The following is a description of a gene set: This event has been computationally inferred from an event that has been demonstrated in another species.<p>The inference is based on the homology mapping from PANTHER. Briefly, reactions for which all involved PhysicalEntities (in input, output and catalyst) have a mapped orthologue/paralogue (for complexes at least 75% of components must have a mapping) are inferred to the other species. part of: p75NTR signals via NF-kB Reactome Pathway: NF-kB is activated and signals survival studied in species Mus musculus electronically inferred by orthology from the curated human pathway, and this is the list of marker genes: Sqstm1, Ngfr, Nfkb1, Ikbkb, Ubb, Irak1, Nfkbia, Ngf, Rps27a, Rela